The following is a description of a gene set: Mouse Gene Set: GOBP_REGULATION_OF_CARDIAC_MUSCLE_CELL_MEMBRANE_POTENTIAL Any process that modulates the establishment or extent of a membrane potential in a cardiac muscle cell (a cardiomyocyte). A membrane potential is the electric potential existing across any membrane arising from charges in the membrane itself and from the charges present in the media on either side of the membrane. studied in species Mus musculus, and this is the list of marker genes: Agrn, Trdn, Atp2a2, Ank2, Slc8a1, Ehd3, Atp1a3, Slc8b1 (NCBI Gene Id 170756), Fxyd1